Given this list of marker genes Rrp1b, Cenpa, Hells, Ncapd3, Trim28, Hdac2, Ezh2, Cbx1, Dnmt3b, Cenpb, Cdkn2a, Incenp, Pcgf2, Orc2, Uhrf2, Anapc7, Sirt1, Ezh1, Cbx3, Hdac1, Mecp2, Baz1a, Sirt2, Tcp1, Chrac1, Wdr76, Lrwd1, A1cf, Igfbp3, H3f4, Sirt6, Pole3, Hmga2, Dnmt3l, Mbd2, Uhrf1, Rrp8, H1f4, Kmt5c, Dnmt3a, Cbx5, Dnmt1, Smarca5, Kdm4b, Smarcad1, Hmga1b, Satb1, Cenpc1, Suv39h2, Cbx2, Zfp618, Kdm4a, Mbd1, Psip1, Mbd3, Bmi1, Macroh2a1, Foxc1, Snai1, Bend3, Zfp57, Tasor, Esco2, Phc2, H1f5, Eed, Sall1, Baz1b, Eme1, Ikzf1, Sumo1, Hsf1, Suv39h1, Nop53, Cbx8, Kdm4c, Cbx6, Flywch1, Daxx, Top2b, Chd5, Rnf2, Ring1, Baz2a, H2al2a, Hmga1, Kdm4d, Morc2a, Ddx6, Tnks1bp1, Sall4, Aldoa, Phc1, Morc2b, H2al1a, Vdr, Uba1, Cbx7, Atrx (NCBI Gene Id 67403), Mphosph8, H2az1, Suz12, here is a description of the gene set: Mouse Gene Set: GOCC_HETEROCHROMATIN species: Mus musculus A compact and highly condensed form of chromatin that is refractory to transcription.